Given this list of marker genes DSG2, DSC2, FLNA, PLXND1, FCGR2A, DYSF, GPC3 (NCBI Gene Id 6394), CFTR, GNPTAB, FNIP1, TLL1, LTBP4, PIGN, HACD1, PKP2, TGFB1, TMEM43, SCO2, TPM3, GTPBP3, CTNNA3, VPS33B, MYH7, CDH2, ALPK3, MYL2, NOTCH1, MMP21, TTN, TRAPPC11, FIBP, TPM2, SREBF1, MYH6, PIGA (NCBI Gene Id 5277), FBXL4, NKX2-5, NKX2-6, EFEMP2, ALG9, KMT2D, GATA4, MAP3K20, TBX5, IPO8, TBX20 (T-box transcription factor 20), JUP, GATA6, ABCA3, CAPNS1, TBX1, LAMB2, GPC4, SELENON, ATP13A3, TGFB3, SGCG, ACTA1, ACTC1, SOX9, SCN5A, NONO, DSP, SLC25A12, NPHP3, ITGA7, COLQ, KDM6A, BTK (NCBI Gene Id 695), CITED2, STAMBP, FOXF1, VIPAS39, PLD1, SFTPB, BMPR2, here is a description of the gene set: Human Gene Set: HP_ABNORMAL_RIGHT_VENTRICLE_MORPHOLOGY Abnormal right ventricle morphology An abnormality of the right ventricle of the heart. studied in species Homo sapiens